The following is a description of a gene set: studied in species Homo sapiens The series of molecular signals initiated by interleukin-3 binding to its receptor on the surface of a target cell, and ending with the regulation of a downstream cellular process, e.g. transcription. Human Gene Set: GOBP_INTERLEUKIN_3_MEDIATED_SIGNALING_PATHWAY, and this is the list of marker genes: IL3, IL3RA, CSF2RB, SYK, STAT5A, FCER1G, JAK2